Given this list of marker genes ABL1, GOT1, ATP5IF1, DCN, KDR, BOK, PPIF, LRRK2, SRC, BCL2, KCNQ3, P2RX7, PPP2R3C, COL6A1, GCLM, HSH2D, ABCD1, RACK1, CDKN2A, FZD9, TSPO, ALB, ADCY10 (adenylate cyclase 10), MYOC, MLLT11, IFI6, PARP1 (poly(ADP-ribose) polymerase 1), GCLC, here is a description of the gene set: The process in which the potential difference across the mitochondrial membrane is reduced from its steady state level. Human Gene Set: GOBP_MITOCHONDRIAL_DEPOLARIZATION species: Homo sapiens